The following is a description of a gene set: Human Gene Set: MIR1911_3P Genes predicted to be targets of miRBase v22 microRNA hsa-miR-1911-3p in miRDB v6.0 with MirTarget v4 prediction scores > 80 (high confidence targets). from publication Chen Y, Wang X (PMID 31504780) species: Homo sapiens, and this is the list of marker genes: CACNB2, TPD52L3, ZNF714, GPR12, VTA1, TMEM126B, TMEM132B, HEYL, FGFR1 (fibroblast growth factor receptor 1), MTCL2, FRK, ZNF100, CLXN (calaxin), WWTR1, FBLN5, ZC2HC1C, KCTD6, HMGB1, SRPRA, ZNF440, PDE4D, OSM, KCNA5, STC1, ZNF69, XKR9, PGM2L1, NUBPL, FAM98B, TIMM17A, KLK15, SP100, ME2, SMAD4, ENTPD7, FOCAD, ACTR1A, CXorf58, CASR, ZNF500, SPRED1, IRX2, NXPE1, PCED1A, NPPC, RCC2